Given this list of marker genes Cr1l, C4bp, Cr2, Cd55, Susd4, Cd46, Trem2, Zp3r (NCBI Gene Id 98633), here is a description of the gene set: Any process that modulates the frequency, rate or extent of the classical pathway of complement activation. studied in species Mus musculus Mouse Gene Set: GOBP_REGULATION_OF_COMPLEMENT_ACTIVATION_CLASSICAL_PATHWAY